Given this list of marker genes CX3CL1, TAFA3, NR1D1, LDLR, PTPRC, GRN (granulin precursor), CST7, SYT11, here is a description of the gene set: studied in species Homo sapiens Any process that stops, prevents or reduces the frequency, rate or extent of microglial cell activation. Human Gene Set: GOBP_NEGATIVE_REGULATION_OF_MICROGLIAL_CELL_ACTIVATION